Given this list of marker genes BAZ1B, TBL2, CREBBP, NCF1, EP300, STX1A, EDNRA, LIMK1, ESR1, DNAJC30, FKBP6, SLC1A3, CLIP2, GTF2IRD1, MLXIPL, TMEM270, VPS37D, TNF, RFC2, SCN1A, GTF2IRD2 (NCBI Gene Id 84163), METTL27, GTF2I, BUD23, ELN (elastin), EIF4H, here is a description of the gene set: species: Homo sapiens Human Gene Set: HP_PHONOPHOBIA An abnormally heightened sensitivity to loud sounds. Phonophobia